The following is a description of a gene set: Removal of the transcription factor SAP1a member of the Ternary Complex Factor (TCF) group of transcription factors which in conjunction with Serum Response Factor (SRF) has been shown to have a profound effect on positive selection in the thymus. When another TCF Elk1 is knocked out in mice there is no effect on positive selection unless it is on a Sap1a KO background where the phenotype is very severe. We have stimulated isolated double positive T cells (DPs) with anti-CD3 to mimic positive selection and compared basal and stimulated transcription across the four genotypes to discover the downstream targets of Sap1a involved in positive selection. Genes up-regulated in untreated double positive thymocytes: ELK4 knockout versus ELK1 and ELK4 knockout. studied in species Homo sapiens from publication Costello P, Nicolas R, Willoughby J, Wasylyk B, Nordheim A, Treisman R (PMID 20554967) Human Gene Set: GSE21546_SAP1A_KO_VS_SAP1A_KO_AND_ELK1_KO_DP_THYMOCYTES_UP, and this is the list of marker genes: LACTB, IRF8, PPM1F, DDX4, P2RY4, BTNL9, DENR, RPA2, CLEC7A, NIBAN2, RND3, NFIL3, OTULINL, SERPINF1, CLEC4E, DGKG, LRATD2, MGAM, IFNAR2, TSR2, SHOC2, GPC1, SLC22A4, PLSCR1, PCGF6, ROPN1L, HACD4, ITGB1, ABHD4, EXT2, PRDX6, DMAC2, GSTM5, CMTM3, CPT2, SLC35G1, KHK, ACVR1, FES, ORC3, RRBP1, CYP4V2, GNL2, ITGAL, XDH, VDAC2, KLK8, FCER1G, ATP6V0E1, MTHFD1L, SSR4, PLEKHA6, TSPO, SLC9A9, STOM, NOSTRIN, ENTPD6, IFRD2, PHETA2, PRSS16, PHF10, HSD17B11, C8orf74, COA8, FKBP9, CCDC158, UBE2J2, BFAR, CISD2, DIXDC1, CLYBL, DNMT3B, TXNDC15, KLF1, EEF1D, PGM3, CX3CR1, PLOD3, SNX7, FFAR2 (NCBI Gene Id 2867), DEPDC7, EMILIN1, MEFV, CCDC40, ZNF35, EMB, ADAMTS3, MRPS23, EIF1AY, ROPN1, EMP3, PAPSS2 (3'-phosphoadenosine 5'-phosphosulfate synthase 2), ZNF623, SCCPDH, SLC16A13, SGMS2 (sphingomyelin synthase 2), TBC1D24 (TBC1 domain family member 24), DIO2, PLA2G15, LTB4R, NAV1, NAP1L5, ARHGAP17, TMEM97, ICAM4, CYB5R1, CERS6, VPS53, ARSA, AK4, ST6GALNAC4, IRF9, SPNS2, LRMDA (leucine rich melanocyte differentiation associated), GATA3, ATP5F1C, NIFK, FAM234A, ABCC2, DYNLT2B, DDX56 (NCBI Gene Id 54606), IL18RAP, ELAC1, RCL1, CHMP4B, SERPINI1, MEAK7, KRT18, PHLPP2, KCNK12, MED7, TMBIM1, MPPE1, RALB, RNF217, DHX35, ADAM12, RBKS, PGAM1, GAA, TLCD1, MSANTD3, PDGFRB (NCBI Gene Id 5159), TMEM126A, WDR55, FKBPL, PALS2, ATF6, SLC19A2, GNL3, ABCD3, EEF1B2, SLPI, PYGL, SNX18, MED22 (NCBI Gene Id 90955), KLHL30, AGPS, HPSE (heparanase), PSMG1, ANO10, NPAS3, SLA, BID, TSEN34, DPH5, PNMA5, TMC8, BMX, XPO5, LTV1, ADIPOR2, GALNS, PLPP5, BORCS6, SIRPA, CD28, DHRS11, GDF3, SIAE, EDEM2 (ER degradation enhancing alpha-mannosidase like protein 2), EEF1G, CPNE2, SFXN2, POGLUT1, C8orf76, PLD1, URGCP (upregulator of cell proliferation), ATP2A1, SORT1, BCAS1, SLC39A11, H3C7, PUS7, NHLRC1, C1GALT1C1, DAAM1, RPAP2 (NCBI Gene Id 79871), TRPS1, AMZ1